Given this list of marker genes Fktn, Dsg4, Serbp1, Trps1, Reg4, Alg2, Phf6, Epha4, Itsn2, Mapkap1, Ccdc32, Zdhhc17, Fam174b, Pcdh19, Slc9b2, Clca3a1, Kmt5a, Camk4, Eif4e, Mbip, Kmt2e, Aebp2, Zfp53, Lsm4, Zfp882, Homer1, Cacnb4, Zscan26, Bbx, Gpr22, Gulp1, Bzw1, Lrrc4c, Itm2b (integral membrane protein 2B), Iqub, Cct8, Mrc2, Lrp4, Pramel34, Ptprr, Prnd, Nlgn1, Sytl5, Kcnh8, Zswim5, Rxrg, Ppp2r5e, Tceanc, Eif2s1, Ablim1, Spcs3, Ugdh, Tph2, Yipf2, Il13ra1 (NCBI Gene Id 16164), Tgfbrap1, Slc8a1, Cybb, Plxna4, Strn3, Mapk8, Dcaf12, Rufy3, Zfp715, Nr4a3, Phc2, Mon1b, Mecp2, Plekhb1, Uvssa, Abtb3, Cers3, Tmem38b, Thrsp, Mab21l1, Bcl11a, Bclaf1, Gnl1, Tox, Prrx1, Fbxo32, Sel1l (NCBI Gene Id 20338), Or2ag2b, Rnft1, Ttc3, Gabra5, Trpc5, Vamp4, Tmem216, Gm14137, Clock, Mab21l2, Emp2, Kbtbd13, Invs, Rnf148, Evi5, Scube1 (signal peptide, CUB domain, EGF-like 1), Golm2, Unc93a, Zbtb18, Slc5a12 (solute carrier family 5 (sodium/glucose cotransporter), member 12), Zbtb10, Pard3b, Cfap418, Klf4, Txndc9, Pdc, Clca3a2, Stk4, Phf8, Mrpl57, Kcnj13, Map7, Cecr2, Cds1, Agap1, Kcnmb2, Ythdf1, Tmem109, here is a description of the gene set: Genes predicted to be targets of miRBase v22 microRNA mmu_miR_7059_3p in miRDB v6.0 with MirTarget v4 prediction scores > 80 (high confidence targets). species: Mus musculus from publication Chen Y, Wang X (PMID 31504780) Mouse Gene Set: MIR_7059_3P